The following is a description of a gene set: Human Gene Set: GNF2_CD14 studied in species Homo sapiens Neighborhood of CD14 Neighborhood of CD14 CD14 molecule in the GNF2 expression compendium, and this is the list of marker genes: AP1S2, CD33, LILRB3, SULT1A1, FGL2, PSAP, CTSS, HCK, LILRA1, SLC7A7, RGS2, TNFAIP2 (NCBI Gene Id 7127), CD14, CD93, FCN1, PLBD1, LILRB2, CD302, VNN1, STX11 (NCBI Gene Id 8676), IFI30 (IFI30 lysosomal thiol reductase), HK3, DUSP1, TBXAS1, MAFB, TYMP, TYROBP, SCO2, LILRA3, CFP, RNF130, MS4A6A (NCBI Gene Id 64231), TLR2, CD1D, NOD2